The following is a description of a gene set: Mouse Gene Set: GOBP_G_PROTEIN_COUPLED_GLUTAMATE_RECEPTOR_SIGNALING_PATHWAY A G protein-coupled receptor signaling pathway initiated by glutamate binding to its receptor on the surface of a target cell, and ending with the regulation of a downstream cellular process. species: Mus musculus, and this is the list of marker genes: Grm2, Grm8, Homer2, Grm3, Grm1, Homer3, Trpm1, Grid2ip, Homer1, Grm6, Grm5, Fyn, Grik3, Grm4, Grm7